The following is a description of a gene set: species: Homo sapiens CD25+ regulatory T cells develop in the thymus (nTregs), but may also be generated in the periphery upon stimulation of naive CD4 T cells under appropriate conditions (iTregs). The mechanisms that regulate the generation of peripheral iTregs are largely unknown. We used microarrays to gain insights into the molecular program of extrathymic Treg development. from publication Prots I, Skapenko A, Lipsky PE, Schulze-Koops H (PMID 21347372) Human Gene Set: GSE24634_NAIVE_CD4_TCELL_VS_DAY7_IL4_CONV_TREG_DN Genes down-regulated in comparison of naive T cells at day 0 versus CD25+ regulatory T cell (Treg) treated with IL4 at day 7., and this is the list of marker genes: CBX5, BIRC5, LBHD1, BCAT2, GOLGB1, SPATS2L, SNF8, GLA, EXO1, IGSF3, ADAM19, IL2RA, FIBP, PPP4C, DCTN2, HMGCL, GSTO1, FHL2, ITPR2, NCKAP1L, BABAM2, HLA-DRB1, WARS1, GFI1, PRC1, CFLAR, MLH1, RAC2, STYXL1, PPP4R1, FAH, RRM2, POLD3, PUDP, NUSAP1, RBBP8, PSMA1, NDUFA7, MCM6, IMMT, FECH (ferrochelatase), RAP1GDS1, ACADVL, MED20, CD2 (NCBI Gene Id 914), PTPN22, GLRX2, RAD51, ATAD2, PARP1, PAICS, DNM1L, ASXL2, RPL39L, GMPPB, PSMB2, KNTC1, NEIL3, CTPS2, NDUFAF1, EXOSC4, ATP5MC1, RFC3, CCNB2 (NCBI Gene Id 9133), COASY, SNRNP25, CD58, KDELR2, PDE4A, PLPP1, NUP62, AURKA, PREB, FIRRM, ANXA2, B3GALT4, NDUFAB1, SQLE, CYB561D2, EPAS1, CRELD2, NME1, KIF2C, CAPG, SLC16A1, RCC1L, SLC43A3, DDB2, VCP, MREG, FUT8 (fucosyltransferase 8), H4C3, PEA15, ACP2, EIF2B2, SLC25A5, PPCDC, PPIA, MRE11, IFI16, SP140, DPAGT1, DHTKD1, LGALS1, SEC61A2, ANXA5, CCR3, GINS1, MYL6B, LSM4, ACOT8, POLR3K, TOX4, CISD1, NIT2, SMARCD2, EZH2, GSTZ1, ATP5MC3, KIF20A, WDR77 (NCBI Gene Id 79084), CKS1B (CDC28 protein kinase regulatory subunit 1B), RPA3, LIMA1, DERL1, PARPBP, DLEU2, MAPK1, CENPE, TARS2, CCT5, TST, MLEC, NASP, TRIB1 (tribbles pseudokinase 1), ACOT9, MRPS12, RFC5, MCM7, EBI3, ITCH, PDIA6, BATF, KEAP1, CDC20, CASP9 (NCBI Gene Id 842), ALDOA, MELK, MGST2, LAPTM4B (NCBI Gene Id 55353), DPP3 (NCBI Gene Id 10072), UQCRQ, TDP1, STAP1, RAB8B, SQOR (NCBI Gene Id 58472), PLTP, BSPRY, GK3, SRF, ESPL1, CTSH, BLVRA, MYO5A, RAD1, FEN1, PSMD14, BUB1, SLBP, BLM, JPT1, GABPB1, PLAAT3, RAB27A, NFIL3, SERPINB1 (serpin family B member 1), LAP3, CCR5, SLC25A20, MTHFD1, FANCL, AKR1A1, CDC7, SEC14L1, ACAT2, PDCL, DHFR, AKR7A2, KIF15, JADE3, CNP, ENTPD1, ILVBL, SMC4, TPX2, TMEM106C, ORMDL2, PSMA5, GNG5, AHI1